Given this list of marker genes SCNN1A, SCN3B, CACNB2, SLMAP, RANGRF, SCN2B, GNAI2, KCNE3, PKP2, CACNA1C, GYG1, SCN5A, AKAP9, TECRL, SEMA3A, SCN10A, ABCC9, JUP, HCN4, TRPM4, KCND3, LMOD2, CACNA2D1, GPD1L, SCN1B, KCNJ8, KCNE5, here is a description of the gene set: Episodes of ventricular tachycardia that have a sudden onset and ending. Human Gene Set: HP_PAROXYSMAL_VENTRICULAR_TACHYCARDIA species: Homo sapiens Paroxysmal ventricular tachycardia